Given this list of marker genes SIGMAR1, PRNP, ADD3, MUSK, HOXA1, CCDC88C, ATXN1, ACOX2, AASS, POLR1A, HLA-DQB1 (major histocompatibility complex, class II, DQ beta 1), NPC2, SPTLC1, NEK9, PSAP, ALS2, MTFMT, VPS13A, NKX6-2, NAXE, UBAP1, SPG11, FA2H, FTL, ELOVL4, POLR3A, SQSTM1, GBA1, POLR3B, SYNJ1, DCTN1, PLP1, FUS, TANGO2, ALDH4A1, VAMP1, DLAT, VCP, ROBO3, PIGT, ACBD6, AGTPBP1, CHCHD10, NOP56, C9orf72, EIF2AK2, SPG7, POLG, PLA2G6, KCNC3, TARDBP, DCC, NPC1, MAPT, TWNK, TBK1, ATP13A2, here is a description of the gene set: Human Gene Set: HP_SUPRANUCLEAR_GAZE_PALSY Supranuclear gaze palsy studied in species Homo sapiens A supranuclear gaze palsy is an inability to look in a particular direction as a result of cerebral impairment. There is a loss of the voluntary aspect of eye movements, but, as the brainstem is still intact, all the reflex conjugate eye movements are normal.